Given this list of marker genes SCO2, ATP6V0A2, SLC33A1, ATP6AP1, AFG2A, ATP7A, TMEM199, COG2, FTH1, CP, ATP7B, AP1S1, AP1B1 (NCBI Gene Id 162), SLC31A1, here is a description of the gene set: species: Homo sapiens Human Gene Set: HP_ABNORMAL_CIRCULATING_COPPER_CONCENTRATION An abnormal concentration of copper. Abnormal circulating copper concentration